The following is a description of a gene set: Concave nail Human Gene Set: HP_CONCAVE_NAIL The natural longitudinal (posterodistal) convex arch is not present or is inverted. species: Homo sapiens, and this is the list of marker genes: KRT1, TRPS1, RNF113A, HOXC13, EDA, AARS1, PLCD1, HRAS, GTF2E2, LMX1B, ERCC2, CARS1, GTF2H5, MPLKIP, RLIM, TARS1, MSX1, TMPRSS6, ERCC3